The following is a description of a gene set: Genes down-regulated in pro-B lymphocytes after knockout of CREBBP. from publication Xu W, Fukuyama T, Ney PA, Wang D, Rehg J, Boyd K, van Deursen JM, Brindle PK (PMID 16424387) studied in species Mus musculus Human Gene Set: XU_CREBBP_TARGETS_DN CREB-binding protein (CBP) and its para-log p300 are transcriptional coactivators that physically or functionally interact with over 320 mammalian and viral proteins, including 36 that are essential for B cells in mice. CBP and p300 are generally considered limiting for transcription, yet their roles in adult cell lineages are largely unknown since homozygous null mutations in either gene or compound heterozygosity cause early embryonic lethality in mice. We tested the hypotheses that CBP and p300 are limiting and that each has unique properties in B cells, by using mice with Cre/LoxP conditional knockout alleles for CBP (CBP(flox)) and p300 (p300(flox)), which carry CD19(Cre) that initiates floxed gene recombination at the pro-B-cell stage. CD19(Cre)-mediated loss of CBP or p300 led to surprisingly modest deficits in B-cell numbers, whereas inactivation of both genes was not tolerated by peripheral B cells. There was a moderate decrease in B-cell receptor (BCR)-responsive gene expression in CBP or p300 homozygous null B cells, suggesting that CBP and p300 are essential for this signaling pathway that is crucial for B-cell homeostasis. These results indicate that individually CBP and p300 are partially limiting beyond the pro-B-cell stage and that other coactivators in B cells cannot replace their combined loss., and this is the list of marker genes: ADAR, ARHGEF2, ADGRE5, OCEL1, NR1H2, ARF6, GSN, NUCB2, CHTF8, ANP32A, RAB14, DIAPH1, TPR, CCR6, FCER2, CCR7, CYTH1, ATP1A1, ETS1, ERCC2, TBC1D10A, PER2, COTL1, HSD11B1, CIITA, LTA, TGFB1, EPHA4, CASP9, ZNF574, RELB, IGHV3-43, KRTAP8-1, ID3, ALDH1A3, IGHV1-2 (NCBI Gene Id 28474), GABRG3, ANKRD17, ZNF444